The following is a description of a gene set: Signaling by LTK in cancer Human Gene Set: REACTOME_SIGNALING_BY_LTK_IN_CANCER species: Homo sapiens, and this is the list of marker genes: CLIP1, MAPK3, PIK3CB, PIK3R2, MAPK1, PIK3CA, PIK3R1